Given this list of marker genes NRBP1, NEXMIF, DDX23, FGFRL1, HMGN3, SCOC, B3GAT1, KRBA1, COQ10A, SURF4, PHTF2, RPGR, GPR85, PAPOLA, YTHDF3, KLHL2, SLITRK3, AAK1, PDAP1, SLC8A1, SPRY2, SLC35F1 (NCBI Gene Id 222553), ATP6V0A2, CNDP1, SULT4A1, BICD2, CTNNA2, CABS1 (NCBI Gene Id 85438), TCOF1, GTF3C4, PLCB4, TSC1, KLHDC8A, RIMS4, CSRP2, SMAD5, SELE, RIMS1, CLK3, ARHGEF4, PACSIN2, WDR26, PDE2A, FCGR1BP, SUN1, SAMD14, HAVCR2, ZNF586, SP4, RALGPS1, PHF24, RBMS3, STK35, EMX2, CD160, ABR, ZBTB43, SPRED1, TENM3, CLN8, NCAM1, SH3GL2, MLH3, CHD6, MYLIP, GALNT15, STRIP2, SLC2A12, SPTB, FBXL3, UBL3, ZNF518A, GPC6, ATP9B, TTC23L, PALLD, FAM53A, WWP1 (WW domain containing E3 ubiquitin protein ligase 1), GSG1L, ATP10A, DICER1, APLP2, SLC25A35, KLF14, GPHN, here is a description of the gene set: Genes predicted to be targets of miRBase v22 microRNA hsa-miR-6529-3p in miRDB v6.0 with MirTarget v4 prediction scores > 80 (high confidence targets). Human Gene Set: MIR6529_3P studied in species Homo sapiens from publication Chen Y, Wang X (PMID 31504780)